The following is a description of a gene set: Human Gene Set: MODULE_26 species: Homo sapiens Genes in the cancer module 26., and this is the list of marker genes: NUDT3, ARMCX5, STRA6, ERVH48-1, ST6GALNAC5, PANK1, RPAP1, GIMAP5, SLC4A5, KCND1, CENPJ (NCBI Gene Id 55835), SLC7A6OS, DSE, TANGO6, CALML3 (NCBI Gene Id 810), WNT6, ARHGEF25, TOX4, ZDHHC4, TLR9 (toll like receptor 9), PRPSAP2, GDF2, GPRC5D, CDYL, ATG4D, LYRM2, MTHFD1L, GDAP1L1, LINGO1, VPS36, RANBP17, ADCK2, SCEL, MPPED1, HSPA4L, MYOT, B3GNT3, AKAP3, IQCA1, INF2, RBFOX2, CDHR2, RASGRP3, DPEP2 (dipeptidase 2), CLDN14, PDE8B, SS18L2, DUS4L, HEBP1, RBCK1, ECEL1, MDM1, TRPM1, EIF2AK4, CD99L2, VDAC3, HINFP, CYP46A1, NECTIN1, HOXC10, SIK3, ACTN2, GJB5, CARD18, TFB1M, NAGPA, APLP1, PBRM1, ANGEL1, DYNC1I1, OR2I1P, MMP27, TYW1, IFT57, ANKRD13A, DNAJC27, COX15, EPB41L4A, DENND5A, DDIT3, ACP4, GALNT13, NTRK3, MZB1, PTGDS, INSIG1, THOC2, BMPR1B, SIPA1L2, SLC7A9, MS4A14, ARID2, AP1S2, SMO, PRTFDC1, KIFC3, GOSR1, NOSIP, BAIAP2 (BAR/IMD domain containing adaptor protein 2), KLHL20, DHX58 (DExH-box helicase 58), KIAA1210, GAL3ST3, AFG2B, MRPL39, EMC9, ADORA1, EEF1G, IFT52, TMEM163, PPP1R17, RPH3A, CD93, NDE1, AGBL5 (NCBI Gene Id 60509), TSKU, TXNDC17, PPDPF, CFL2, AFAP1-AS1, KLHL41, ACTR3B, SPOCK3, ACTR6, FMNL2 (formin like 2), CRNN, SMURF2, LTV1, TRIT1, OGDHL, DNAJC14 (NCBI Gene Id 85406), PDE8A, RTN2, FAHD2A, DLGAP2, AQP2, FAIM2, ZRANB1, ARSB (arylsulfatase B), LINC01549, SST, TM2D1, NSFL1C, ERO1B, NRIP3, SNTG2, VAPB, MSTO1 (NCBI Gene Id 55154), CSGALNACT2, TFR2, TBC1D15, SLC22A16, ZNF655, FBXL4 (F-box and leucine rich repeat protein 4), FAXC, MRPL36, SH2B2, KHDC1, TRAF7, ZKSCAN5, SYT6, SERTAD4, LGI2, BAG2, BBOX1, NSD1, FLRT3, CCDC62, UQCR10, MRRF, SLC7A10, SPG11, LINC00869, CXCL13, UBE2T, TMEM144, AAR2, DOP1B, PHLPP2, APBB1IP, CPNE4, SEZ6L2, PHF24, MXRA8 (matrix remodeling associated 8, NCBI Gene Id 84308), MED8, SLC10A2, ZHX2, GDA, ATPAF2, TRIM2, FBXO34, PAXBP1, TRIM5, YJU2 (NCBI Gene Id 55702), FA2H (fatty acid 2-hydroxylase), PECR, FOXF2, NLN, KLF1, SNTG1, CLOCK, INTS13, FARP2, CAP2, LRTM1, MAP3K13, TP53RK